Given this list of marker genes LIAS, MOCOS, TST, CTU2, MPST, MOCS3, MOCS2, TRMU, NFS1, TSTD1, here is a description of the gene set: Human Gene Set: GOMF_SULFURTRANSFERASE_ACTIVITY studied in species Homo sapiens Catalysis of the transfer of sulfur atoms from one compound (donor) to another (acceptor).